The following is a description of a gene set: studied in species Homo sapiens Human Gene Set: GSE32423_MEMORY_VS_NAIVE_CD8_TCELL_UP Effects of IL-4 on CD8 T cells functions are largely unknown. IL-4 induces survival and proliferation of CD8 T cells, but several studies suggest that IL-4 could also affect several functions of CD8 T cells such as cytotoxicity. Our team has shown that IL-4 repress the expression of Ccl5 in vitro. To define more precisely the impact of IL-4 on CD8 T cells, we performed a whole genome expression microarray analysis of naive and memory CD8 T cells cultured in presence or absence of IL-4. This approach allowed us to define the IL4-gene-expression signature on CD8 T cells. from publication Ventre E, Brinza L, Schicklin S, Mafille J, Coupet CA, Marçais A, Djebali S, Jubin V, Walzer T, Marvel J (PMID 22942430) Genes up-regulated in comparison of memory CD8 T cells versus naive CD8 T cells., and this is the list of marker genes: SP7, S100A6, PTPDC1, FGF22, SHD, NUAK2, TSPAN31, TRAF1, ERRFI1, TRIM2, MYL4, TMPRSS13, TBKBP1, INPPL1, GLMP, SEC16B, SPRY2, FAT1, IFITM10, CFH, MSC, CXCR5, PITX3, BCL2L14, FASLG, GPC1, PPM1J, KIF5C, DNAJA4, HLA-A, LEP, CDH1, CCL5, ANKZF1, CLSTN1, PSORS1C2, CPNE2, CYP4A11, CRMP1, DIRAS1, PRSS12 (NCBI Gene Id 8492), ST14, FITM1 (NCBI Gene Id 161247), SBF2, LRR1 (leucine rich repeat protein 1), SDF2, CEBPB, LAMC2, NIBAN3, CIMIP2C, TERB2 (NCBI Gene Id 145645), CLDN12, TASL, CHST11, DPEP3, MACROD1, NXPH4, SNX8, TMEM89, CA12, PLAT, FAM161A (FAM161 centrosomal protein A), NXPH3, ATF3, ADARB1, TBX21, MRI1, BANK1, SPINT2, CASP1, ACOT7, SPAG16, BMPR1A (bone morphogenetic protein receptor type 1A), IFNG, PRDM1, RGL3, DPYSL4, HOPX, HOXB7, NFIL3, TGDS, ARHGEF28, NEFH, RUNDC3A, CXCR3, TMC8, CA11, TNFRSF25, BCL2A1, KIAA0040 (NCBI Gene Id 9674), LHPP, PRKCZ, CORO7, YBX3, ZNF175, ABHD14A, KCNK6 (potassium two pore domain channel subfamily K member 6), CD200R1L, NACC2, SERF1A, AHNAK, AZIN2, DDR1, PMP2, PSEN2, GCAT, RHCG, PGLYRP1, ECI1, GPR183, LGALS1, PLEKHM3, SAMHD1, EPHA8, OSTF1, RHOB, ANKS4B, NTRK2, ACSBG1, CAMK2N1 (NCBI Gene Id 55450), THBS4, DENND5A, ART3, VKORC1, ENPP1, LHX1, GUCY2D, CCKBR, CRLF2, DAO, KIF17 (NCBI Gene Id 57576), GSTT1, MAP3K5, PDE8A, PIEZO1, PUM3, IGSF23, RPP21, TTC39A, ADAP1, BARHL1, ZDHHC2, CFAP276, FBLN5, CSDC2, ASAP2, OR51B4, PALMD, CD86, ST8SIA5, CTLA4, CHIC1, LSR, SOAT2, RUNX2, ROGDI, GRAP, PTPN13, NECTIN2, ANKH, REG4, PRKCE, TMBIM1, ACKR1, NT5E, HPS1, MARCHF10, GIMAP7, TAL2, AIG1, SLC25A22, NRG1 (NCBI Gene Id 653104), TRPC5, GSAP, KCTD17, SERPINB6, PGLS (NCBI Gene Id 25796), PCTP, C10orf120, RHOBTB1, CIMIP4, PRSS41, ASNS, CAPG, MEPE, ANXA2, AGAP1, DNAJC4, GM2A, EFNA1, CIMIP5, FBXW8, RRAD (RRAD, Ras related glycolysis inhibitor and calcium channel regulator), PGBD1, CSTPP1, RGS1, ARSB, ECSIT, NAAA, NCF4